The following is a description of a gene set: Mouse Gene Set: CUI_LANGERHANS_IL15_RESPONSE_UP Genes positively differentially expressed in cell type: Langerhans upon treatment with cytokine: IL-15 in mouse lymph nodes in vivo. from publication Cui A, Huang T, Li S, Ma A, Pérez JL, Sander C, Keskin DB, Wu CJ, Fraenkel E, Hacohen N (PMID 38057668) studied in species Mus musculus Cytokines mediate cell-cell communication in the immune system and represent important therapeutic targets. A myriad of studies have highlighted their central role in immune function, yet we lack a global view of the cellular responses of each immune cell type to each cytokine. To address this gap, the authors created the Immune Dictionary, a compendium of single-cell transcriptomic profiles of more than 17 immune cell types in response to each of 86 cytokines (>1,400 cytokine-cell type combinations) in mouse lymph nodes in vivo. A cytokine-centric view of the dictionary revealed that most cytokines induce highly cell-type-specific responses. For example, the inflammatory cytokine interleukin-1β induces distinct gene programmes in almost every cell type. A cell-type-centric view of the dictionary identified more than 66 cytokine-driven cellular polarization states across immune cell types, including previously uncharacterized states such as an interleukin-18-induced polyfunctional natural killer cell state., and this is the list of marker genes: Igtp, Bst2, Zbp1, Ptpn1, Cd274, Gbp2 (guanylate binding protein 2), Bcl2l11, Irgm1, Irgm2, Cxcl10, Isg15, Ifi47, Stat1 (NCBI Gene Id 98183), Serpina3g, Cxcl9